The following is a description of a gene set: from publication Yevshin I, Sharipov R, Kolmykov S, Kondrakhin Y, Kolpakov F (PMID 30445619) studied in species Homo sapiens Human Gene Set: GREB1_TARGET_GENES Genes containing one or more binding sites for (GREB1) in their promoter regions (TSS -1000,+100 bp) as identified by GTRD version 20.06 ChIP-seq harmonization., and this is the list of marker genes: ERG, FER1L4, DNAH3, ERVW-1, DSCAM-AS1, FREM2, MIR4259, DGKA, LRG1, NNT, FAM111B, NAB2, IFRD1, ZMYM2, PLXNB1, ARID1B, NKAIN4, KCTD11, LINC02652, CFAP276, GREB1, ZNF395 (zinc finger protein 395), LINC02620, VILL, TCF25, LINC01344, HK1, CEP83, OXR1, LAD1, VPS72, SPAG17, FHDC1, FMO9P, FAM107B, RNU6-1013P, ALKBH6, LRCH4, NT5DC3, LLGL2, KLK6, ABCC5-AS1, RTKN, TTC39A-AS1, MIR9-3HG, LINC00963, NR1D1, TUBA1A, P4HB, IGSF3, EPN3, ZNF750, MCCC2, SNHG10, TMEM241, ENSG00000275765, ZNF77 (zinc finger protein 77), FAM83A, GTPBP3, CAMTA1-DT, LINC00111, CHD8, NCOA4, PRUNE1, MIR99AHG (NCBI Gene Id 54079), RGS17P1, PARD3 (par-3 family cell polarity regulator), KCNK1, FRYL, AFAP1, ADGRG1, PTMA, GATAD2B (GATA zinc finger domain containing 2B), GLRX5, AP3M2, TMEM229B, OSBPL8, MIR4328, EXOSC10, WDR81, NFATC2, MTMR4, BLTP2, CAB39L, NAV2-AS3, ENSG00000229425, LINC01555, CCNP, DDX47, STX16, MIR3168, RFX1, KIF21A, DOLPP1, SWINGN, KHSRP, TRAF7, BCL3, TBC1D10B, RFFL, HNRNPA1, ALDH1A2, HRCT1, ENSG00000270571, RBM47, KCNJ13, SPTSSB, TMEM79, MPHOSPH10, KLF6, LNC-LBCS, ASCC2, GSN, FMN1, TMEM184B, MTA1, DNPEP, PTPRH, RNF207-AS1, KAT7, SCAMP4, LINC02952, SLC38A2-AS1, IDE, GAS5, PSMA3-AS1, PMEL, ADIRF-AS1, LINC02747, LENG1, MACROD1, CARD10, ST6GALNAC4, PRR11, TRIM31 (NCBI Gene Id 88008), PRADC1, CHD6, MGST1, LCOR, MICOS10-NBL1, PCDH1, MGRN1, UFSP1, GPR160, VAV3, LINC01213, GPRC5A, KYAT1, ZSWIM1, TNKS1BP1, MIR5093, ATP2A2, MICOS10-DT, PRR15L, TCIRG1, KRTAP3-1, OSBPL10, ANXA9, ABCA3, SSTR5-AS1, SALL4, MIR6811, UPF1, MAP4K3-DT, P2RY6, THSD4, EGFL8, PGP, BCAR1, CAPN8, MESP1, ENSG00000233017 (NCBI Gene Id 105372710), LINC02343, ATP8B1, CLNK, B3GALNT1, ZNF860, KPNB1, SUCLA2-AS1, FAM72A, CRACR2A, HSH2D, LINC02518, SLC39A1, INPP4B, EHF, RAD51B, NMT1, VAMP5, CEACAM16-AS1, COPZ1, ACTG1P25, DLC1, SKA1, DRC3, NEMP1, LRIG3, ANKRD39, AGAP2, AKAP1, ZDHHC1, ZNF44, NDUFAF8, PRSS23 (serine protease 23), EPS8, HDGFL2, ARID4A, PAM, BTNL12P, ABHD17C, TMC1, CHST12, MSMO1, JUND, NAIF1, DNMT1, VIRMA, TDRKH, SEC14L5, MIR563, EPG5, SLC11A2, LINC01900, DCAF15, RPS6KL1, TMPOP2, RAB5B, TBX2-AS1, FAM117A, TAFAZZIN, ELAPOR1, ZNF687-AS1, PKIB, NFYB, BRWD1, KIAA1217, LINC02130, RARA, EML6, TNK2, CLN8, AKAP9, MIR635, ENSG00000267288, KARS1P3, PKP4-AS1, STAP2, SCRIB, TRIM29, BTG1-DT, FAM178B, LTBP3, FBXO24, TOM1L2, HSPB8 (heat shock protein family B (small) member 8), MANEAL, NACA4P, TSPAN1, RHPN1-AS1, RBBP8, CANT1, ATF3, MAF1, ADIPOQ, STARD10, RBBP8NL (RBBP8 N-terminal like), DNAAF1, RPL39P5, LINC01484, PXMP4, ANAPC2, MIDN, DNAI1, TPD52L2, STC2, LINC01975, LCEP1 (late cornified envelope pseudogene 1), EVI5L, ZNF689, C9orf152, S100A2, ZDHHC1P1, C7orf57, AKAP8L, ADIRF, MEF2C-AS1, SNX31 (NCBI Gene Id 169166), PRPF40B, TRAPPC2, SPPL2B, FNTAP2, PDK4-AS1, LINC02926, LINC00536, FAAP24, TGM1, NCAM2, CLVS1, CRPPA, SLC2A8, LINC01978, OXR1-AS1, SHARPIN, PKD1L2, TMBIM1, ARRDC4, RBL2, PXDN, FBXO38, RHOBTB3, IGSF9, SLC25A25, PDZK1 (NCBI Gene Id 96133), ZFYVE28, ALKBH3-AS1, GFAP, ANKFY1, CYLD, STX16-NPEPL1, POU2F3, SLC25A42, PLXNB2, CELSR1, RPL32P9, RPL7P30, GRHL2-DT, PPARD, TEDC1, COL4A2, BCL9L, IGLC4, HIGD1AP13, ZNF687, XRCC3, PRKACA, ISG20, EPN2, S100A11, RPS15AP29, MIOS, TGFBI, EPHA1 (NCBI Gene Id 2041), CARINH, EHMT1, SIN3A (SIN3 transcription regulator family member A), NDRG1, TMPRSS4, PPP1R16A (NCBI Gene Id 84988), CYP1B1, SYBU, MCF2L, RHPN1, RADIL, RASAL1, CUL3, MEF2A, RNF5, AKT1, DLG5, SPRYD3, RGS3, MIR203A, PLA2G6, DAZAP1 (DAZ associated protein 1), LINC00511, VEPH1, NADK, LIMA1, IFT43, PROSER1, STON1-GTF2A1L, FAM174B (NCBI Gene Id 400451), ENPP3, SMIM6, FOXN3, STK16P1, SLC1A5, TNS1, CYP1B1-AS1, ZSWIM4 (NCBI Gene Id 65249), C5AR2, IGLJ4, MATCAP2, TMTC2, PNPLA7, SPG7, USF3, SEPTIN9, CD276, BLVRB, CDKN2C, MIR4513, THADA, SEMA3B, CSNK1G2, LINC01431, PAIP2B, BCAR3, ZNF574, MIR3622B, SGMS2 (sphingomyelin synthase 2), ERCC1, IQSEC1, HRG-AS1, FXYD6-AS1, SNORD59A, SMARCD2, LINC00885, RECQL5, DKFZP434A062, MIR550A2, COMT, DUSP13B, DYNLT3, MAPKAP1, CEP170B, G3BP1, EIF2AK3-DT, PHF5A, HDAC7, LINC02408, DMXL1-DT, IQCD, VPS26C, DDA1, RNU6-1220P, TH, TMEM45A, CCDC88C-DT, ERGIC1, CDS1, LINC02707, LINC02950, DOCK4, IKZF2, SLC29A1, EPHB4, CDC34, LAMB1, MIR5707, DNM2, TXNP5, STX19, PCTP, CCDC183, RHOC, MAB21L3, C4orf36, RNA5SP160, RAPGEFL1, PLEC, TOP2A, DMXL1, EEA1, ASCL2, NLRP7P1, IGF2BP1, ZMYM5, SULT1A1, MYL11, FAM234B, IFT27, TRAPPC9, EIF2AK3, DNAH17, CYTH2, HERC1, LINC01082, ADGRF4, UST-AS2, ANKRD2, ANP32E, PPM1H, KDM4B, LMBR1, GRAMD1A, SRGAP2, MIR550A1, UTRN, SRP72P2, ISOC2, RPL37P4, CD22, AK2, NECTIN4-AS1 (NECTIN4 antisense RNA 1), EVL, TMPRSS6, HMCN1, CORO2A, P2RX7, MIR6775, KMT5C, ZNRF1, SIDT2, PLA2G4B, KRT7-AS, XXYLT1, KPNB1-DT, ANKFN1, AKAP1-DT, MPV17L2, EPB41L1, RNU6-1105P, AFF1, KATNB1, ZRANB2-DT, SUCLA2, ANKRD23, SKIL, ALDH3B2, PBX1, PNKD, ACAP2, JUP, ENSG00000265246, ENSG00000266313, LINC00479, NFKBIZ, TMPRSS3, MIX23, MIR4479, ATP6V0A4, RFWD3, COQ8A, SRRM2-AS1, MIR550B1, VLDLR-AS1, PRDX3P2, S100A16, EPS8L2, ATP5F1B, PRKCH, ZNF552, GSTP1, TRIB1, PYROXD2, MIR3181, ARMH4, PPFIA3, C1orf21, PSMG3, RTN4, PABPN1, PUM2, LINC02015, ADH7, ADAMTSL5, MYORG, TJP2, ZFYVE21, CREBRF, ZBTB3, VMP1, ZNF410, GATAD2A, ITGB2, SPTBN4, LINC01508 (long intergenic non-protein coding RNA 1508), PRSS27, TBC1D3P1-DHX40P1, TLE1, IGF1R, DNAJB5-DT, FAM86EP, SLC38A2, MTUS1, NFATC2IP, MPRIP-AS1, RPL32P30, H2AZ2, RDH10-AS1 (NCBI Gene Id 101926926), SPRY4-AS1, ADARB1, TMEM160, PREX1 (phosphatidylinositol-3,4,5-trisphosphate dependent Rac exchange factor 1), SDK2, SMAD3, KCNH2, ADAP1 (NCBI Gene Id 11033), MGP, GRAMD1A-AS1, MIR5684, LINC02102, ANKRD22, ENSG00000268460, FRMD6, GSPT1, RNF207, ATP5MC1, NIPSNAP2, RGMB, ZNF564, TPD52L1, GCLM, BATF, SSNA1, PITX1-AS1, SAMD8, CCNYL7, MIR3188, EHD1, CNOT3, TBC1D8, LY6E-DT, PRKCD, TPRN, ACTL6A, RAI14-DT (NCBI Gene Id 105374723), PIK3AP1, ENSG00000251574, ABCC11, PWWP2A, NIPSNAP1, NRP1, ZNF669, LINC01656, ENSG00000253824 (NCBI Gene Id 124901990), TMEM94, SLC10A3, WDR90, RNU6-197P, FAM171A1, DMRT2, PROSER3, RNF224, CLCN3, HYCC1, PIK3C2G (phosphatidylinositol-4-phosphate 3-kinase catalytic subunit type 2 gamma), LINC00475, PLAC1, RNU2-8P, MYZAP, EMC6, TBC1D16, LINC01275, MIR6715A, ADAT3, CYB561, TSPAN9, LINC01588, SH2D3C, PLEKHF2, SPAG7, MRPL15P1, FAM47E, S100A7, HSPB6, ZNF823, TIPARP, RANBP2, BBOF1, CITED2, CDH26, HPN, LINC01701, PROSER2, S100A10, S100A4, CD59, MLLT3, NCOA1 (NCBI Gene Id 8648), LINC00879, IL17REL, GOT1-DT, ID1, BMAL1, MAPK10, CHD3, MED24, TBX2, CCR3, TAX1BP3, PPM1L, PYM1, CCDC88C, MUC5B, RNU6-490P, CNGB1, VWA3B, ENSG00000254337, PIP5KL1, CEP89, IKBKG, BDKRB1, ATXN7L1, WIPI1, GIGYF2, ETNK2, SEC14L2, SLC6A6, ROBO3, SLC25A36, MICOS10, DCUN1D4, DOK7, SNORD114-1, SLC16A3, LFNG, SLC44A2, LMCD1, VCP, RAB26, CASP7, TMEM60, AKNAD1, PHTF2, RPL27A, PKP3, PDGFD, NLK, CNOT1 (NCBI Gene Id 51579), CIC, HNRNPC, CRNDE, FAM86B3P, LINC00824, ENC1, AMZ1, CDH13-AS2, PACRG-AS1, ALKBH7 (alkB homolog 7), LRRFIP1, FAM86GP, LY6L, PDK2, MCF2L2, TUBA1C, CTSB, TJP1, FNIP2, LINC01016, C1QTNF6, TEPSIN, PCBP1-AS1, NOP14-AS1, NINL, TBKBP1, LPP, GPNMB, SLC45A4, PRICKLE2-AS3, DNAH11, RPL5P7, ERBB2, MARCKSL1P2, CFAP45, LASP1, CA12, MIR638, CCDC40, DAAM1, DRAIC, SNX9, HNRNPL, SSR4P1, NFKBIA, YIF1A, AGPAT1, SLC19A3, ENSG00000225676, OSBPL2, SLC9A8, MIR6715B, BFSP2-AS1, MIDEAS (NCBI Gene Id 91748), TUBB4B, NCF4-AS1, LRIG2, CLN8-AS1, SSTR5, RNU2-17P (NCBI Gene Id 106480204), DNMBP, SYTL5, PIWIL4, DNAJC5B, LDLRAD4 (NCBI Gene Id 753), UNC13D (NCBI Gene Id 201294), TRAF2, GOT1, KDM5A, LINC00216, RECQL4 (RecQ like helicase 4), DCAF7, MPND, CAMTA1, MIR4530, RCOR3, IBA57, PSCA, VBP1, SLC38A1, DOP1B, TMED3, KRT80 (NCBI Gene Id 144501), UBE2C, RN7SL211P, ARHGEF1, TFAP2C, RABL3, SREBF1, MAP3K3, ENSG00000227619, H2AZ2-DT, NAALADL2, TMPRSS11F, RPS29P8, MCRIP2, PAK4, CCT7, MACC1, LINC00112, POLR3K (NCBI Gene Id 51728), ANKRD11, BAIAP3, PRECSIT, SPTLC2, RPS10P7, CYP4F23P, INHA, MRPL30P1, GOLPH3L, FAF1, STOX2, DENND2D, F7, DGAT2, SLC26A1, PPP4R1L, RBM20, TMEM210, SCNN1A, GRHL2, PKD2L2, ZNF444, CRKL, TDRKH-AS1, SPRED2 (sprouty related EVH1 domain containing 2), TPRG1, MGC32805, TIPARP-AS1, TBL1X, SLC38A4-AS1, CARMIL3, NUDT16-DT, FPR1, ERP27, BCAS3, TFF1, AKR1E2, SLC35E1, STIP1, BRME1, SRI, SRPK1, ABHD2, RPS6KA2 (ribosomal protein S6 kinase A2), SVOPL, NAGK, C1orf162, NUMA1, CHI3L2 (NCBI Gene Id 9155), CDH11, AP5B1, CACTIN-AS1, AP2A1, OVOL2, PDGFB, ZKSCAN1, PROM2, LRRC58, WWC1, RGMB-AS1, TACC2, SYT8, ARRDC1, SERPINA1, TMCO3, SLC27A2, IFITM10, TTLL5, CCN5, FKBP4, RNF19A, TAL2, SLC17A9, CD63, LINC03013, IQANK1, ENSG00000228044, GALNT10, COMTD1, SCGB1D2, ECH1, PHPT1, ENSA, ZNF282, AMOTL2, ERLNC1, DNAJB5, CMTR2 (NCBI Gene Id 55783), DCTN4, CHPT1, SPECC1L, PRSS22, FBRS, SNRNP25, KLHL25, TBCD, COQ8B, GRHL1 (grainyhead like transcription factor 1), SPNS2, BICDL1 (NCBI Gene Id 92558), ENSG00000278899, MTMR12, CDK2AP2, STAT3, CCDC159, MIR550B2, RC3H1, LNCATV (lncRNA negative regulator of antiviral signaling), ATG9B, ODAM, NUDT16, SKA2, UMODL1, ALDH3B1, SLC20A2, AHCYL2, PDSS1, TMEM120A, CCDC192, UIMC1, CHTF18, RNU6-563P (RNA, U6 small nuclear 563, pseudogene), KRT7, KRT8, ZMYND8, UNKL, SMAGP, LUCAT1, FRMD4B, DNASE1, TMPRSS13, GCOM1, RC3H1-DT, ST6GAL1, ENSG00000267698, PRRT1B, SCIN, SLC7A2, WSB2, SH3YL1, ZBTB37 (zinc finger and BTB domain containing 37), HEBP2, SLC51B, HMGCS1, ESRP2, RNU6-813P, URB1 (URB1 ribosome biogenesis homolog, NCBI Gene Id 9875), ENSG00000263745, WWP1, RGS10, TMEM105